Given this list of marker genes CD47, ARPC5, B2M, RPS3, RPL36AL, HMGN1, CCND3, EIF3G, ENO1, SPCS2, MT-CO1, SNRPG, CDC42, HOPX, PSME1, ID2, JUNB, XBP1, TMSB4X (thymosin beta 4 X-linked), CYRIB, ATP6V0E1, CCL4, UCP2, COPE, TPM3, RPL14, LAPTM5, GZMH, CD53, EIF1, STK17A (serine/threonine kinase 17a), MYOM2, CTSD, DHRS7, RBM8A, CD7, PRR13, DOK2, FLNA, TBC1D10C, TRAPPC1, GMFG, CLIC3, FYB1, RPL6, RPL21, CD37, PTP4A2, COX8A, ACTR3, RPS27A, CALM1, PSME2, GLRX, CLEC2B, PTPRC, UFC1, GZMA, CD69, DBI, PTMA, PPP1CA, IER2, BTG1, RPS3A, ABRACL, RAP1B, SEC11A, ETS1, EIF4A1, SH3BGRL3, FGFBP2, KLRF1, C1orf56, RPSA, KLRD1, HNRNPF, SUB1, NKG7, LCK, CIB1, ALOX5AP, RPS29, TSC22D3, PLAAT4, TMA7, GHITM, NDUFA12 (NCBI Gene Id 55967), IL2RG, STK4, ACTB, CD52, LIMD2, SSR2, LITAF, CD247, JUN, ARHGDIB, TPST2, PRELID1, CUTA, LCP1, CMC1, CASP4, LSM14A, CKLF, OSTC, ACTG1, SELENOT, RPS2, AKR1C3, XCL2, CCL5, GNG2, CTSW, BIN2, NPM1, ANXA1, GPR65, NDUFB3, CORO1A, SRGN, CYBA, PARK7, CD164, DRAP1, EMP3, SPON2, ACP1 (acid phosphatase 1), IL2RB, UBL5, C12orf75, PTGDR, RPL27, GZMM, PFN1, S100A4, RPL28, CLIC1, RBM3 (RNA binding motif protein 3), SAMD3, UBE2D3, KLRC1, GZMB, CDC42SE1, CCL3, MYL12A, H3-3B, KLRB1, CST7, C1orf162, RPL15, FCGR3A, SLC38A2, HCST, TPM4, RPLP1, ATP5MG, PABPC1 (NCBI Gene Id 26986), OSTF1, CD48, PYHIN1, CD99, ITGB2, MSN, SERF2, PSMA7 (NCBI Gene Id 5688), HNRNPDL, RPS27, PAXX, ARPC5L, HSPA5, ARPC1B, NDUFB11, NDUFB2, SNRPB, PPP1R18, C11orf58, UBB, GIMAP4, PLAC8, FCER1G, RPL23A, JAK1, YWHAZ, PLEK, DDIT4, PDIA3, TUBB, RAC2, IGF2R, CTSC, RPS19, OST4, GADD45B (NCBI Gene Id 4616), GPSM3, ATP5F1E (NCBI Gene Id 514), RPL41, CAPZB, ATP5MC2, ARPC2, ARPC3, TLE5, IFITM2, RPS15A, VAMP8, UBE2D2, HSPA8, SARAF, SCP2, CYCS, HNRNPA1, TYROBP, PTPRCAP, CAP1, GNLY, PRF1, CFL1, DAZAP2, EVL, ZFP36L2, RPS26, PSMB9, TMED2, SFT2D1, PPP2R5C, here is a description of the gene set: from publication Rubenstein AB, Smith GR, Raue U, Begue G, Minchev K, Ruf-Zamojski F, Nair VD, Wang X, Zhou L, Zaslavsky E, Trappe TA, Trappe S, Sealfon SC (PMID 31937892) Human Gene Set: RUBENSTEIN_SKELETAL_MUSCLE_NK_CELLS studied in species Homo sapiens